Given this list of marker genes Bbs4, Drd2, Ghrhr, Nppc, Slc6a3, Csf1, Sgip1, Gpat4, Ncor1, Mbd5, Ghsr, Ikzf1, Vil1, Npy1r, G6pdx, Ankrd26, Tnks2, App, Mfsd2a, Fosl2 (fos-like antigen 2), Stat3, Bcl2, Plac8, Atp8a2, Gdf5, Socs2, Atrn, Adrb3, Dio3, Igf2, Tshr, Ghrh, Gh, Ghr, Chd7, Stat5b, H19, Pou1f1 (POU domain, class 1, transcription factor 1), Mkks, Sod1, Dlg1, Azgp1, Nipbl, Fxn, Sh3pxd2b, Alms1, Lgmn, Sptbn4, Celf1, Foxs1, Pik3ca, Gdf15, Cacna2d2, Agt, Atxn2, Ppib, Adrb2, Adrb1, Pex5 (NCBI Gene Id 19305), Ezr, Afg3l2, Smo, Flt3, Drd3, Stc2, Spr, Hsf1, Hmga2, Rai1, Gpr21, Fto, Pls1, Bbs2, Hdac3, Pou3f2, Prlh, Gamt, Gpam, Suv39h1, Siah1a, Stat5a, Zfp640, Htra2, Ptch1, Sgpl1, Creb1, Zmpste24 (zinc metallopeptidase, STE24), Gnas, Daxx, here is a description of the gene set: Any process that modulates the frequency, rate or extent of growth of the body of an organism so that it reaches its usual body size. Mouse Gene Set: GOBP_REGULATION_OF_MULTICELLULAR_ORGANISM_GROWTH species: Mus musculus